Given this list of marker genes Syk, Slc18b1, Fcgr3, Slc18a2, Maob, Slc29a3, Hrh3, Htr1a, Slc22a3, Slc18a3, Snca, Fev, Slc29a4, Lgals3, Fcer1g, Slc22a1, Htr1b, Xbp1, Nos1, Itgb3, Cnr1, Cd300a, Gpm6b, Slc6a4, Slc18a1, Slc22a2, Htr7, Fcer1a, P2rx1, Crh, Crhr2 (NCBI Gene Id 12922), here is a description of the gene set: studied in species Mus musculus Mouse Gene Set: GOBP_SEROTONIN_TRANSPORT The directed movement of serotonin into, out of or within a cell, or between cells, by means of some agent such as a transporter or pore. Serotonin (5-hydroxytryptamine) is a monoamine neurotransmitter occurring in the peripheral and central nervous systems.